Given this list of marker genes VAMP2, FCER1A, VAMP8, CCL3, CCR2, VAMP7, CD300A, IGHE, F2RL1, STX4, here is a description of the gene set: The change in morphology and behavior of a eosinophil resulting from exposure to a cytokine, chemokine, cellular ligand, or soluble factor. Human Gene Set: GOBP_EOSINOPHIL_ACTIVATION studied in species Homo sapiens